The following is a description of a gene set: part of: G2/M Transition studied in species Homo sapiens Reactome Pathway: Regulation of PLK1 Activity at G2/M Transition The kinase activity of PLK1 is required for cell cycle progression as PLK1 phosphorylates and regulates a number of cellular proteins during mitosis. Centrosomic AURKA (Aurora A kinase), catalytically activated through AJUBA facilitated autophosphorylation on threonine residue T288 at G2/M transition, activates PLK1 on centrosomes by phosphorylating threonine residue T210 of PLK1, critical for PLK1 activity, in the presence of BORA. Once activated, PLK1 phosphorylates BORA and targets it for ubiquitination mediated degradation by SCF-beta-TrCP ubiquitin ligases. Degradation of BORA is thought to allow PLK1 to interact with other substrates (Seki, Coppinger, Du et al. 2008, Seki et al. 2008).<br><br>The interaction of PLK1 with OPTN (optineurin) provides a negative-feedback mechanism for regulation of PLK1 activity. Phosphorylated PLK1 binds and phosphorylates OPTN associated with the Golgi membrane GTPase RAB8, promoting dissociation of OPTN from Golgi and translocation of OPTN to the nucleus. Phosphorylated OPTN facilitates the mitotic phosphorylation of the myosin phosphatase subunit PPP1R12A (MYPT1) and myosin phosphatase activation. The myosin phosphatase complex dephosphorylates threonine residue T210 of PLK1 and inactivates PLK1., and this is the list of marker genes: OFD1, TUBA4A (tubulin alpha 4a), CEP135, CCNB2, CDK5RAP2, CEP152, NEDD1, NEK2, DCTN3, UBC, PPP1R12A, CEP72, UBB, HAUS6, ALMS1, CSNK1E, CEP63, MAPRE1, HAUS5, SKP1, CEP43, OPTN, TUBB4B, CEP76, HAUS2, DYNC1I2, TUBG1 (tubulin gamma 1), DYNC1H1, PPP2R1A, CEP164, PRKACA, HAUS7, AJUBA, HSP90AA1, CEP131, CETN2 (NCBI Gene Id 812), HAUS1, CDK1, HAUS3, BTRC, PLK1, HAUS4, NDE1, CNTRL, CEP78 (centrosomal protein 78), PPP1CB, HAUS8, CPAP, RPS27A, SDCCAG8, CSNK1D, PRKAR2B, DCTN1, DYNLL1, PLK4, SFI1, YWHAG, PCNT, YWHAE, BORA, CEP57, UBA52, TUBA1A, CEP290, CEP41, TUBB (tubulin beta class I), RAB8A, PCM1, AKAP9, ACTR1A, CEP250, CCP110, CEP192, PPP1R12B, SSNA1, FBXW11, PAFAH1B1, CCNB1 (cyclin B1), AURKA, NINL, CUL1, CLASP1, TUBB4A, DCTN2, CKAP5, ODF2, CEP70